Given this list of marker genes PSMB6, PSMA4, PSMB7, PSMD2, OMA1, UBB (NCBI Gene Id 91253), PSMC1, PSMC3, PSMD7, PSMA6, PSMC2, PSMA3, PSMA5, PSMD14, PSMC5, PSMD13, PSMD11, ADRM1, PSMB1, PSMB2, PSMD12, PAK2, RPS27A, PSMD6 (NCBI Gene Id 9861), SEM1, ARHGAP10, PSMD1, PSMA7, UBA52 (ubiquitin A-52 residue ribosomal protein fusion product 1), PSMB4, PSMA2, PSMA1, PSMD3, UBC, PSMB3, OPA1 (OPA1 mitochondrial dynamin like GTPase), PSMB5, PSMC4, PSMD8, PSMC6, here is a description of the gene set: Regulation of Apoptosis Human Gene Set: REACTOME_REGULATION_OF_APOPTOSIS species: Homo sapiens